Given this list of marker genes MIB1, LY96, CMKLR1, SNX27, TM9SF4, POLR1E, CLN6, TMEM50A, NCKIPSD, RGP1, DUSP1, GBP4, TLR1, PCDHB9, CD84, SLC35G1, MINPP1, LY86, IRAK3, RASGRP1, LCLAT1, TMEM39B, HOXA11, TMF1, GCGR, SLC40A1, OCRL, BAMBI, KCNA3, MTMR2, TIE1, NLN, DDX60, LRP6, TRAF5, CPT2, MIR217, LGALS3BP, FAM193A, RFFL, ZP3, TMEM59, SCRG1, IL10RB, ATP6V0C, KLHL36, NR2F1, HACD4, SLC11A1, DNMT3L, GPR108, SLC19A2, SCARB2, HSDL1, MIR1-1, DOP1B, RPIA, TRAPPC10, XKRX, MBP, GAMT, UGT2A3, SCN7A, ITM2A (NCBI Gene Id 9452), AOAH, LDHB, NFATC2IP, CXCL13, FAM20C, FREM3, CDK5RAP3, TENT4A, DSC1, CLIC6, XPR1, MAGEB18 (NCBI Gene Id 286514), CTSD, PCNX3, FLVCR1, GZF1 (NCBI Gene Id 64412), IMPACT, PRSS3P1, RTTN, SLC15A4, ARRB2, ARHGEF3, IKBKE, ODF4, NEURL3, PHKA1, LPIN1, KRTAP16-1, MIR384, VPS26C, OSBPL11, PCTP, SNX5, PLAUR, PRRC1, RNF185, PYCR3, TFEC, FRMD4B (NCBI Gene Id 23150), FBXO24, ITGAL, FPGT, ADAM10, DENND6A, DCLRE1C, TMEM154, ADGRE4P, KLHL1, P2RX4, PRKRIP1 (PRKR interacting protein 1), LCE1B, ZCCHC2, SLC28A2, FUNDC2, AXL (NCBI Gene Id 558), CALHM6, TMEM218 (transmembrane protein 218), VPS33A, DENND10, MIR380, SH3KBP1, SELENON, CMBL, CDKL5, RING1 (NCBI Gene Id 6015), NAALAD2, CHCHD5 (coiled-coil-helix-coiled-coil-helix domain containing 5), LCP2, RAB5C, P2RY12, PREX1, here is a description of the gene set: studied in species Homo sapiens Dendritic cells (DCs) process and present self and foreign antigens to induce tolerance or immunity. In vitro models suggest that induction of immunity is controlled by regulating the presentation of antigen, but little is known about how DCs control antigen presentation in vivo. To examine antigen processing and presentation in vivo we specifically targeted antigens to the two major subsets of DCs using chimeric monoclonal antibodies. Unlike CD8+ DCs that express the cell surface protein CD205, CD8- DCs, which are positive for the 33D1 antigen, are specialized for presentation on MHC class II. This difference in antigen processing is intrinsic to the DC subsets and associated with increased expression of proteins associated with MHC processing. Human Gene Set: GSE6259_33D1_POS_DC_VS_CD8_TCELL_DN from publication Dudziak D, Kamphorst AO, Heidkamp GF, Buchholz VR, Trumpfheller C, Yamazaki S, Cheong C, Liu K, Lee HW, Park CG, Steinman RM, Nussenzweig MC (PMID 17204652) Genes down-regulated in splenic 33D1+ dendritic cells versus CD8 T cells.